The following is a description of a gene set: Human Gene Set: HP_RECURRENT_HYPOGLYCEMIA Recurrent episodes of decreased concentration of glucose in the blood. Recurrent hypoglycemia studied in species Homo sapiens, and this is the list of marker genes: SLC22A5, ACSL5, ALG12, BCS1L, PAK1, UCP2, MEN1, MRAP, INSR, YY1, NAB2, PHKB, STAT6, HMGCL, MC2R, KCNJ11, NFKB2 (nuclear factor kappa B subunit 2), ROBO1, GCK, MPV17, PPP1R15B (protein phosphatase 1 regulatory subunit 15B)